The following is a description of a gene set: Any process that results in a change in state or activity of a cell (in terms of movement, secretion, enzyme production, gene expression, etc.) as a result of an epinephrine stimulus. Epinephrine is a catecholamine that has the formula C9H13NO3; it is secreted by the adrenal medulla to act as a hormone, and released by certain neurons to act as a neurotransmitter active in the central nervous system. Human Gene Set: GOBP_CELLULAR_RESPONSE_TO_EPINEPHRINE_STIMULUS species: Homo sapiens, and this is the list of marker genes: SIRT2, SNCA, PDE4B, ADIPOQ, SRD5A1, KCNQ1, SLC9A1, RYR2, PDE4D, PRKACA, PKLR, ATP2B4